Given this list of marker genes OXCT1, ACAT2, HMGCS1, BDH1, ACAT1, here is a description of the gene set: species: Homo sapiens Human Gene Set: WP_DISORDERS_IN_KETOLYSIS Disorders in ketolysis